Given this list of marker genes MMACHC, IFT27, EIF4H, CWC27, BBS4, MAN2B1, EIF2S3, TBL2, TAPT1, SDCCAG8, MINPP1, EED, NUP107, NSD1, ERCC2, TBX22, PMM2, GRIA4, TRMT10A, SCLT1, MKS1, ZNF699, ERCC8, FGFR2, PAK3, ADAT3, ALG3, DSE, MASP1, CLIP2, PHIP, PLCH1, YME1L1, RBMX, WDR73, CLCN3, MID2, PSMB8, AP3D1, OTUD7A, BBS9, NCF1 (NCBI Gene Id 653844), PIEZO2, SLC12A6, RAB3GAP2, SCAPER, RAB18, ITGB6, CHD8, ZFX, ZIC2 (NCBI Gene Id 7546), METTL5, SMG8, MPLKIP, ERCC6, BBS2, MBTPS1, GRIA3, NPHP1, GPR101, SSR4, PHGDH, CENPE, CIT, SHOC2, TOE1, RPL10, SLC2A10, ALG9, GTF2I, NALCN, ZNF711, BMP4, RNU4-2, SUZ12, KDM6A, NDE1, FDFT1, NAA10, METTL27, OSGEP, IFT74 (intraflagellar transport 74), KCNJ1, THOC2, TBC1D20, CEP290, MAP2K2, BAZ1B, SHANK3, TP53RK, GLI2, ITGA3, EZH2, EYA1, BBS12, ZBTB20 (zinc finger and BTB domain containing 20), ERCC1, QRICH1, PCLO, GTF2IRD2, YRDC, LIMK1, SLC16A2, AIP, STEEP1, SMC1A, SIN3A, GLB1, COLEC11, SYNGAP1, ERI1, PGAP1, PRDX1, NHS (NHS actin remodeling regulator), ZNHIT3, ANKRD11, PPP1R15B, ZNF526, BBS7, JAG1, CPE, PIK3R1, CHRNA1, DPYSL5, MAN1B1, TTI2, RFC2, SLC9A6, DPF2, CNTNAP2, COLEC10, CBL, KDM5C, GNB2, SLC6A17, PACS1, DNAJC30, DDB1, MAP2K1, AEBP1, NEXMIF, FMR1, TENM3, TOR1A, POLR1A (NCBI Gene Id 90784), AHSG, PTDSS1, CHRNA7, CA2, HECTD4, BUD23, WDR4, NDP, HDAC4, ATP6V1B2, LZTFL1, TBC1D23, SLC4A10, OTUD6B, LAGE3, TBCD, ODC1, SMC3, AKT1, NBN, TTC8, ELN, TMEM270, HHAT, MBTPS2, NARS1 (NCBI Gene Id 9243), TAFAZZIN, TRIO, WDPCP, CEP19, BRD4, TRAPPC9, BBS10, TRIM32, ATP6V1A, PTEN, FKBP6, KCNH1, MED13L, SNAP29, MGP, CTU2, PTCH1, VPS37D, DHX30, HDAC8, GTF2IRD1 (GTF2I repeat domain containing 1), IFT172, DYRK1A, BBIP1, STX1A, BBS5, SMARCA2, LMBRD2, ASNS, KDM6B, KANSL1, TBL1XR1, IDH1, KATNB1, ZNF668, MECP2, EFEMP1, NUP133 (NCBI Gene Id 55746), TNPO2, ADAMTSL1, FBXO11, MKKS, ERCC4, KRAS, SLC2A1, KCNN3, TAF1, COG3, KIFBP, TRPS1, FIBP, PRUNE1, INSR, FLNA, ALKBH8, UBE2A, CLIC2, PPP1CB, PIGN, PAX1, HECW2, SOX6, PYCR2, ARL6, RMRP, GON7, RDH11, BRAF, ALDH18A1, FAR1, CASK, SALL1, SUOX, KDM4B, HERC1, TAF4, NECTIN1, IQSEC2, RHOBTB2, AGPAT2, CTCF, FTSJ1, AP1S2, TAF6, PQBP1, KMT2D, CEP120, BBS1, BSCL2, CACNA2D1, DENND5A, AGO1, PHF6, NIPBL, SET, TPRKB, RAD21, LSS, CFAP418, RAB3GAP1, OPHN1, CHST14, BRWD3, IPO8, SYNE1, MGAT2, here is a description of the gene set: Macrotia Human Gene Set: HP_MACROTIA species: Homo sapiens Median longitudinal ear length greater than two standard deviations above the mean and median ear width greater than two standard deviations above the mean (objective); or, apparent increase in length and width of the pinna (subjective).